The following is a description of a gene set: from publication Chen Y, Wang X (PMID 31504780) Mouse Gene Set: MIR_1231_3P Genes predicted to be targets of miRBase v22 microRNA mmu_miR_1231_3p in miRDB v6.0 with MirTarget v4 prediction scores > 80 (high confidence targets). studied in species Mus musculus, and this is the list of marker genes: Strn, Anpep, Tmem150c, Ankrd44, Tef, Cfap97d1, Tsc22d2, Iars2, Kansl1l, Alox12, Lmtk2, Mrpl15, Fhip2a, Cdk19, Cntnap2, Zbtb4, Rassf6, Igdcc4, Tacc1, Dcaf7, Notch3, Sort1, Slc2a4, Zbtb47, Dlgap1, Ccs, Cbx7, Pgpep1, Zfp516, Dynll1, Cyfip2, Snx30, Birc5, Raf1, Tmtc2, Il31ra, Ppfia2, Igsf10, Lsm12, Gga2, Gpc1, Cmtr1, Fscn3, Cdk16, Cdca7l, Zbtb37 (zinc finger and BTB domain containing 37), Cpq, Inava, Sdc3, Aebp1, Trib2, Zfp2, Ptpn12, Ccdc137, Gpr176, Cpeb4, Brdt, Arl4c, Mfhas1, Tbx2, Bace1, Mllt6, Fmr1, Mknk2, Bltp3b, Pyurf, Pwwp2a, Fgf14, Extl3, Ftcd, Satb2